Given this list of marker genes PTPN22, NOD2, NOD1, VIM, CHMP5, TRIM41 (tripartite motif containing 41), RIPK2, LDOC1, ARHGEF2, IRF5, here is a description of the gene set: species: Homo sapiens Any process that results in a change in state or activity of a cell (in terms of movement, secretion, enzyme production, gene expression, etc.) as a result of a muramyl dipeptide stimulus. Muramyl dipeptide is derived from peptidoglycan. Human Gene Set: GOBP_CELLULAR_RESPONSE_TO_MURAMYL_DIPEPTIDE